The following is a description of a gene set: studied in species Homo sapiens Human Gene Set: GSE33424_CD161_HIGH_VS_NEG_CD8_TCELL_DN We used microarray to compare gene expression between CD161++/CD161+/CD161-CD8+ T cells from human cord blood. from publication Walker LJ, Kang YH, Smith MO, Tharmalingham H, Ramamurthy N, Fleming VM, Sahgal N, Leslie A, Oo Y, Geremia A, Scriba TJ, Hanekom WA, Lauer GM, Lantz O, Adams DH, Powrie F, Barnes E, Klenerman P (PMID 22086415) Genes down-regulated in CD8 T cells: KLRB1 high versus KLRB1-., and this is the list of marker genes: PCNA, UCP1, AEBP1, AKR1B15, COL1A2, HPCAL1, UTF1, EIPR1, HLA-A, SELENOH, AP2S1, CD8B, HNRNPLL, IRS2, SLC46A1, RAD51, AIRE, ID3, HAUS5, SATB1, SRCIN1, CA1, MRPL54, NDUFA2, PSPH, CNGA1, NCKAP1 (NCK associated protein 1, NCBI Gene Id 9864), GATA3, BAG2, CCR9, CD8A, PSMB3, CD28, TOP2A, TNFAIP8L1, MYO6, DHRS3, CBR1, EDEM1, ATP5MK, PTPN13, KRT77, MRPL55, THY1, CDC25C, BIRC5, GPATCH2, FBLN1, REXO1, PALM, CDCA3, GFI1, EZH2, YJU2, USP3 (ubiquitin specific peptidase 3), CKAP2, ACIN1, RFC5, EGR2, LAPTM5, RBP1, CST7, SSRP1, MCM2, CCNA2, MMP7, NCBP1, MRPS28, IDS (iduronate 2-sulfatase), CDC20, G0S2, ZAP70, CELSR1, CPSF4, FAS, CENPK, NDUFB6, ALYREF, CIT, CUTA, NFE2, RPL41, ROM1, RGS10, ACKR1, LAG3, MCM7, CD3G, H3-4, RGCC, PSAT1, METTL9 (NCBI Gene Id 51108), SPEG, LPIN1, PFKP, MS4A6A, SLC29A1, FADS1, F2R (NCBI Gene Id 2149), C11orf54, CHCHD7, PSME2, AHCY, CD3D, MAD2L1, TES, MTR, SRI, NPTX1 (neuronal pentraxin 1), DDC, RECK, FAM53A, RACGAP1, MATN1, PRC1, NVL, TDRP (testis development related protein), F2RL1, SNHG6, STMN1, SGK1, TCF20, MYBBP1A, NDN, PDK1, CDCA8, COL4A1 (NCBI Gene Id 1282), AFF1, HOXA4, NSG2, HYAL2, CMC2, IDNK, IL7R, SSBP2, RFLNB, FYN, MAP4K4, SEMA4F (NCBI Gene Id 9408), PSMB6, NRP1, THOC7, PIM3, MT1E (NCBI Gene Id 4493), LAMB3, ZBTB7B, ATP5PF, GOSR1, BRCA1, VPS26B, TCF7, SIT1, SH3PXD2A, RAMP1, ACTN2, FRMD6, MRPL41, CDK1, SLC12A7, C8orf33, ADA, ITK, ATP5IF1 (NCBI Gene Id 93974), FGF13, XRCC1, ADH1C, CD3E, NUSAP1, SUPT4H1, STAT4, ITM2A, ANLN, MPHOSPH9, RANBP1, ARL4C, EVL, MYBL2, CHEK1, NOCT, CKS1B, UQCRQ, CRCT1, CCNB2, MRPL27, PELI1, NUDT1, FBN1, KIF1A, DRC1, FZD6, PCLAF, KIF22, HMGCR, BZW2, ELOVL6, LCK, TXK, TP53I13, NOTCH1